Given this list of marker genes Ace, Ctsh, Ece1, Lnpep, Mme, here is a description of the gene set: Mouse Gene Set: GOBP_NEUROPEPTIDE_CATABOLIC_PROCESS species: Mus musculus The chemical reactions and pathways resulting in the breakdown of neuropeptides. Neuropeptides are signaling peptides that travel across a synaptic junction.